Given this list of marker genes PRIM2, MCM3, POLA2, PRIM1, POLA1 (DNA polymerase alpha 1, catalytic subunit), here is a description of the gene set: A complex of four polypeptides, comprising large and small DNA polymerase alpha subunits and two primase subunits, which are capable of catalyzing the synthesis of an RNA primer on the lagging strand of replicating DNA and the subsequent synthesis of a small stretch of DNA. The smaller of the two primase subunits alone can catalyze oligoribonucleotide synthesis. species: Homo sapiens Human Gene Set: GOCC_ALPHA_DNA_POLYMERASE_PRIMASE_COMPLEX